Given this list of marker genes Rnf167, Atg16l1, Slc15a4, Tpcn2, Clec16a, Tasl, Abcb6, here is a description of the gene set: Mouse Gene Set: GOCC_ENDOLYSOSOME_MEMBRANE species: Mus musculus The lipid bilayer surrounding an endolysosome. An endolysosome is a transient hybrid organelle formed by fusion of a late endosome with a lysosome.